The following is a description of a gene set: studied in species Homo sapiens Human Gene Set: HP_HYPOPLASTIC_DERMOEPIDERMAL_HEMIDESMOSOMES Underdeveloped hemidesmosomes at the dermoepidermal junction. Hemidesmosomes are the specialized junctional complexes, that contribute to the attachment of epithelial cells to the underlying basement membrane in stratified and other complex epithelia, such as the skin. Hypoplastic dermoepidermal hemidesmosomes, and this is the list of marker genes: PLEC, LAMA3, LAMC2, COL17A1, LAMB3, ITGA6, ITGB4